The following is a description of a gene set: Human Gene Set: REACTOME_REGULATED_NECROSIS studied in species Homo sapiens Regulated Necrosis, and this is the list of marker genes: HSP90AA1, PDCD6IP, UBC, CASP8, UBB, GZMB, CDC37, ITCH, FASLG, FAS, HMGB1, BIRC3, IRF1, FADD, XIAP, CFLAR, SDCBP, CHMP4A, STUB1, PELI1, CASP3, IL18, BAX (NCBI Gene Id 581), FLOT1, RPS27A, RIPK1, IL1B, CHMP3, CASP1, IL1A, TNFSF10, CHMP4B, CYCS, RIPK3, OGT, PRKN, BAK1, TRAF2, TNFRSF10A, GSDME, TP63, IRF2, TP53, CASP4, FLOT2, BIRC2 (baculoviral IAP repeat containing 2), CHMP4C, TRADD, CHMP2B, TNFRSF10B, CHMP7, UBA52, GSDMD, CHMP2A, UBE2L3, CASP5, ELANE, MLKL, CHMP6